The following is a description of a gene set: from publication Marigo I, Bosio E, Solito S, Mesa C, Fernandez A, Dolcetti L, Ugel S, Sonda N, Bicciato S, Falisi E, Calabrese F, Basso G, Zanovello P, Cozzi E, Mandruzzato S, Bronte V (PMID 20605485) Genes down-regulated in CD11b Spleen from BALBc mouse versus CD11b BoneMarrow from BALBc mouse incubated with GMCSF and GCSF. Tumor growth is associated with a profound alteration of myelopoiesis, leading to recruitment of immunosuppressive cells known as myeloid-derived suppressor cells (MDSCs). Analyzing the cytokines affecting myelo-monocytic differentiation produced by various experimental tumors, we found that GM-CSF, G-CSF, and IL-6 allowed a rapid generation of MDSCs from precursors present in mouse and human bone marrow (BM). BM-MDSCs induced by GM-CSF+IL-6 possessed the highest tolerogenic activity, as revealed by the ability to impair the priming of IFN- -producing CD8+ T cells upon in vivo adoptive transfer. Moreover, adoptive transfer of syngeneic, GM-CSF+IL-6-conditioned MDSCs to diabetic mice transplanted with allogeneic pancreatic islets resulted in long term acceptance of the allograft and correction of the diabetic status. Cytokines inducing MDSCs acted on a common molecular pathway. Immunoregulatory activity of both tumor-induced and BM-derived MDSCs was entirely dependent on C/EBP transcription factor, a key component of the emergency myelopoiesis triggered by stress and inflammation. Adoptive transfer of tumor antigen-specific CD8+ T lymphocytes resulted in therapy of established tumors only in mice lacking C/EBP in myeloid compartment. These data unveil another link between inflammation and cancer and identify a novel molecular target to control tumor-induced immune suppression. We used gene expression analysis to identify those factors, secreted by tumor-infiltrating MDSC, which could drive emathopoiesis. Moreover we compare gene expression profile of tumor-induced MDSC, obtained from either the spleen and the tumor infiltrate of tumor bearing mice, and in vitro bone marrow-derived MDSC. species: Homo sapiens Human Gene Set: GSE21927_SPLEEN_MONOCYTE_VS_GMCSF_GCSF_BONE_MARROW_DN, and this is the list of marker genes: ANKRD13A, ANK3, TLR10, JMY, MAGOH-DT, ZNF41, SDHAF1 (succinate dehydrogenase complex assembly factor 1), OSBPL3, SNX6, ZDHHC14, NICOL1, PNPLA3, APBB1IP, SOD1, NIPA1, PIK3AP1, GUSBP1, PCYOX1, LMO4, BASP1, SSB, COPS9, ATP2B1, SDR9C7, PSIP1, BEX2, TMEM132B, PLEKHO2, FKBP11, CD82, TXN (thioredoxin), JADE3, PKHD1L1, NAA50, DENND1B, TRIM47, CD1D, GS1-24F4.2, DDX28, FAM200A, AGK, ADCK2, PDLIM1, FASTK, ELMOD1, MCM2, HAUS8, BMPR1A, CSNK1G1, MROH2B, ZC2HC1A, GLB1, FGD6, GDAP1, CRIP1, GUSBP5, PRKCZ, RNF8, CSRP1, NUDCD3, UMPS, ATP6V0E1, C19orf53, TMIGD2, LYPD5, NQO2, MEF2C (NCBI Gene Id 4208), ZNF770, URGCP, NT5DC1, CCNE1, LY86, PIK3R2, RPLP2, EPCIP, CARS1, ITPRIPL2, JAM3, NDFIP1, CYRIA, ZNF844, TRPC5OS, SLC9A1, RNF168, PKIG, LTB, MAML2, SLC25A26, JUN, COQ3, FMR1NB, TMEM101, SAMSN1, ACAT1, NME3 (NME/NM23 nucleoside diphosphate kinase 3), INPP5F (NCBI Gene Id 22876), SPAG7, MRPS21, MSTO1, TPRG1L, CD80, RNF133, DPAGT1, FAS, GAPDH, ELK3, MSMO1, ILDR1, NFS1, CXCR2, EARS2, OSBP2, PTCD1, ZDHHC6, TCEAL4, TLR4, PLAG1, TC2N, PRORP, FMO9P, SEC24B-AS1, NBPF10 (NBPF member 10), KRTAP4-9, MNDA, IL6, IFI30, MYH8, SNHG12, IL12RB1, CA4, INPP5A, TOR3A (torsin family 3 member A), CKAP4, SMS, MTR, NLRC3, TMEM8B, XPO1, BACE2, PPP1R13B, SPTLC2 (NCBI Gene Id 9517), SRC (SRC proto-oncogene, non-receptor tyrosine kinase), CD99, CD58, G3BP2, PLEKHB1, ACP5, TAF9B (NCBI Gene Id 51616), AFDN, LY96, ZNF589, TRERF1, SMARCA2, VAMP1, ID3, POU6F1, MDFIC, PUS1, WAPL, KLF10, FAU, MIF4GD, MCOLN2, DDX18, S100A10, SNAP25, PLCG2, ANTXR2, PPP1R36, BOLA3, NIBAN1, ZBTB20, BNIPL, BTNL9, FKBP14, KBTBD8, FN3KRP, TIMM10, MAP3K20, IDNK, PLAAT4, PAG1, ADAMTS6, INTS7, TMEM198B, DVL1, ZNF35, ATAD2, TNK1, PLXNC1, EEFSEC, KIF13A, CISD1, TMEM14B, ZBTB4, STUB1-DT